Given this list of marker genes Dtx1, Tsc22d3, Pik3ip1, Ccnd3, Rbm3, here is a description of the gene set: Cytokines mediate cell-cell communication in the immune system and represent important therapeutic targets. A myriad of studies have highlighted their central role in immune function, yet we lack a global view of the cellular responses of each immune cell type to each cytokine. To address this gap, the authors created the Immune Dictionary, a compendium of single-cell transcriptomic profiles of more than 17 immune cell types in response to each of 86 cytokines (>1,400 cytokine-cell type combinations) in mouse lymph nodes in vivo. A cytokine-centric view of the dictionary revealed that most cytokines induce highly cell-type-specific responses. For example, the inflammatory cytokine interleukin-1β induces distinct gene programmes in almost every cell type. A cell-type-centric view of the dictionary identified more than 66 cytokine-driven cellular polarization states across immune cell types, including previously uncharacterized states such as an interleukin-18-induced polyfunctional natural killer cell state. Genes positively differentially expressed in cell type: Treg upon treatment with cytokine: LIF in mouse lymph nodes in vivo. Mouse Gene Set: CUI_TREG_LIF_RESPONSE_UP studied in species Mus musculus from publication Cui A, Huang T, Li S, Ma A, Pérez JL, Sander C, Keskin DB, Wu CJ, Fraenkel E, Hacohen N (PMID 38057668)